The following is a description of a gene set: species: Mus musculus Any process that increases the rate, frequency or extent of a necroptotic process, a necrotic cell death process that results from the activation of endogenous cellular processes, such as signaling involving death domain receptors or Toll-like receptors. Mouse Gene Set: GOBP_POSITIVE_REGULATION_OF_NECROPTOTIC_PROCESS, and this is the list of marker genes: Ripk1, Zbp1, Ripk3, Parp1, Casp6, Aifm1